Given this list of marker genes TGFBR2, GRHL2, SEC24B, SHH, FGFR2, LIF, FOXF1, IGF1, here is a description of the gene set: The biological process whose specific outcome is the progression of a lung lobe from an initial condition to its mature state. This process begins with the formation of a lung lobe by branching morphogenesis and ends with the mature structure. A lung lobe is one of the rounded projections that compose the lung. Human Gene Set: GOBP_LUNG_LOBE_DEVELOPMENT species: Homo sapiens